Given this list of marker genes NLN, ZEB1, MTOR, FGF9, BCL2, TBX1, OLFM2, HDAC9, PAK1, MYLK3, SUPT6H, MESP1, MIR22, RGS2, SOD2, LAMC1, ARRB2, MIR199B, RBM38, EFEMP2, TARBP2, HDAC1 (NCBI Gene Id 3065), TGFB1 (transforming growth factor beta 1), MIR34A, TCF23 (NCBI Gene Id 150921), SETD3, GSK3A, MDM2, GPER1, RCAN1, MMP14, SRF, ACTN3, ZBED6, MIR1-1, RBM24, TRIM32, TNPO2, LAMA1, RGS4, DNMT1, CAMK1, FOXO4, FBXO22, HDAC3, TOMM70, AKIRIN2, BDNF, MYOD1, FZD7, NFATC2, AKAP6, MIR590, HDAC4, PPARA, KIT, MYF5, MIR206, MIR133B, G6PD, LAMA2, MIR208A, MIR424, MEF2C, NFATC1, NID1, MEGF10, MIR19B1, PIEZO1, RBPMS2, MIR100, DMPK, CEACAM5, BMP4, CCN3, OR10J5, SIRT1, YBX1, CTH, XBP1, MAPK12, PDGFB, MECP2, BMP2, PRDM6, SMYD1, LAMB2 (laminin subunit beta 2), PDCD4, PIAS1, HEY2, RBM4 (NCBI Gene Id 5936), MIR26A1, MIR221, PI16 (peptidase inhibitor 16), BHLHA15, TMEM119, MIR140, IGF1, BMPR2, MAPK14, DKK1, MIR204, MIR200B, KAT2A (lysine acetyltransferase 2A), NOTCH4, EFNB2 (ephrin B2), SHOX2, IGF2, MIR125B1, HEY1, PLPP7, SIK1, DLL1, MIR222, MIR145, TRIM72, NOTCH2, CAV3, NFATC3, SMARCD3, MAML1, MSX1, NOTCH1, CCNT2, MIR133A1, PARP2, HDAC5, MAPK11, SMAD1, ENG, MYF6, EREG, FOXP1, CYP26B1, PTBP1, HOPX, SHH, MYOG, PRKD1, WNT3A, BMP10, MIR18A, SOX6, NKX2-5, PROX1, LMOD3, MIR15B, BHLHE41, EDN1, MIR19A, FRS2, ATP11A, SMAD4, NRG1, MIR199A1, YY1, RPL3L, MIR499A, MIR21 (microRNA 21), CDK9, MED28, MAMSTR (NCBI Gene Id 284358), ID2, NACA, LAMB1, CTDP1, BMPR1A, MYOCD, FGFR2 (fibroblast growth factor receptor 2), EZH2, here is a description of the gene set: Human Gene Set: GOBP_REGULATION_OF_MUSCLE_CELL_DIFFERENTIATION Any process that modulates the frequency, rate or extent of muscle cell differentiation. studied in species Homo sapiens